The following is a description of a gene set: Human Gene Set: MIR3193 Genes predicted to be targets of miRBase v22 microRNA hsa-miR-3193 in miRDB v6.0 with MirTarget v4 prediction scores > 80 (high confidence targets). species: Homo sapiens from publication Chen Y, Wang X (PMID 31504780), and this is the list of marker genes: MUS81, SURF6, EML4, UBXN8, PRRC1, AIPL1, SPEN